The following is a description of a gene set: Mouse Gene Set: GOCC_COMPLEX_OF_COLLAGEN_TRIMERS A complex of collagen trimers such as a fibril or collagen network. studied in species Mus musculus, and this is the list of marker genes: Col10a1, Col4a4, Col3a1, Col4a3, Col5a1, Col5a3 (NCBI Gene Id 53867), Col11a2, Col2a1, Col4a6, Col5a2, Col4a2, Col27a1, Col4a5, Lum, Col28a1, Col11a1, Col1a2, Col1a1, Col4a1